Given this list of marker genes ANXA4, AXIN1, SAR1B, ABHD8, TLE3, TBX18, MIR519A1, MMP14 (matrix metallopeptidase 14), MIR107, ASH1L, MAPK8IP2, EMILIN1, ZNF675, SHISA6, MAPK14, PDE4D, RNF126, SH3RF1, EGFL7, NOTCH1, RASGRF1, PLK2, MIR23A, PRMT1, ARHGAP44, MIR19B1, RASA4B, MIR342, LDLR, THY1, MYOZ1, PTPRD, ADAR, ZGPAT, MIR4691, CLU, DUSP5, RRM2B, NDUFC2, ADORA1, SLC35C1, PTTG1IP, PRDX2, TRIM40, PDE3B, FHL2, ABCC8, HTRA2 (NCBI Gene Id 27429), MTNR1B, CTTN, OAS1, FOXO3, CHRD, PLEKHA1, IL1B, CSNK1E, PKIA, BCL9L (NCBI Gene Id 283149), CREB3L1, PTPRJ, NLRC3, RAB11FIP3, EGFR, PYCR1, CTH, SFRP5, ACVR1, FGF10, ARHGAP29, PELI3, CRH, CNOT2, KLF7, NCOR2 (nuclear receptor corepressor 2), GATA1 (NCBI Gene Id 2623), YWHAB, PRKCQ, PPM1A, USP25, TANK, METTL3, PAK5, OSM, PPM1B, RGS8, MINAR1, IQSEC2, SOD2, RGS16, RASA2, HMGA2, SEC13, PPP5C, FRZB, AMBP, GSTP1, HEY2, APPL1, SAG, TRIM67 (tripartite motif containing 67), VEPH1, MIR503, FMR1, SINHCAF, DEPDC5, VHL, IFI6, PLCL2, PBLD, CTNNB1, HMGXB4, RUNX2, NODAL, DSG3, PP2D1, FRMD8P1, GLI1, KCNB1, CD72, ENO1, NEDD4, MTOR, NOMO1, MIR125A, YTHDF3, CRY2, HLA-G, PDCD6, VSNL1, TGFBR1, MIR573, VRK3, OGT, TREX1, VWC2L, CACTIN, APC, GRB10, UBE2N, ACTN3, SRF, RGS6, RGS20, USP47, BARX1 (NCBI Gene Id 56033), TNF, WNT5A, RASSF2, TBC1D10C, SIN3A, TRIM60, PLD2, MIR27A, SOST, FKBP1B, MIR19A, SERPINE2, CAV2, ALPK2, NR2F2, TRIM15, GNAZ, PPT1, PPIA, BICD1, DEFB114, NPHP4, LMNA, TLR6, DLX2, FIGNL1, IGFBP2, MAPKBP1, CARD8, RNF43, ATF4, INS (NCBI Gene Id 3630), TWIST1, PDCD4, CD2AP, HSPA1B, CER1, MORN3, DUSP22, PPP3CB, XIAP, IL6ST, TLE1, CD160 (CD160 molecule), DUSP16, TNFAIP8L1 (NCBI Gene Id 126282), SPRED3 (sprouty related EVH1 domain containing 3), CIB1, UBE2D1, PHPT1, DEPTOR, AARS2, DKK3, BDNF, YWHAZ, GRID2IP, FGG, HIF1A, TP53, EID2, NDRG2, SCAI, KIF26A, AKT1, PRKCD, SAMTOR, IL1R2, IL36RN, NFATC4, OFD1, IL10, MAPK7, MVP, WDR24, HIC1, GABBR1, TAX1BP3 (Tax1 binding protein 3), PPP6C, IL6, MIR181A2, TMEM170B, TXNDC12, TMBIM6, KLF4, DAND5 (NCBI Gene Id 199699), MAPKAPK5, TRIM59, HADH, PPP2R1A, SERPINE1, DUSP6, IL17RD, TMBIM1, IRS1, TCF7L2, EPO, MFHAS1, PRDM15, PTPRR, CNOT7, CCDC125, APLNR, PIAS2, SYNJ2BP, PRKAR2B, XBP1, CCDC22, MCL1, CCDC88C, MIR206, DLX1, TRIAP1, OTUD3, NRROS, TERT, UFD1 (NCBI Gene Id 7353), LRRC14, ITPRIP, WFIKKN1, MIR130A, TAF9B, RTKN2, KIF7, LPAR1, MAP3K20, IL19, LBH, EZR, OTUD5, TBC1D7, DCST1, FERMT1, MYOC, MMP3, EPN2, KREMEN1, CAVIN3, RNF115, NPRL3, WWC3, MUC1, ELL3, RASL11B, HIPK3, SAP130, GRIK3, INSIG2, HHIP, CSNK1A1L, CARD16 (NCBI Gene Id 114769), PTPN2, MAP2K1, MIR302B, DUSP26, DDIAS, TLR4, SH2B3, RPGRIP1L, CXXC4, UBR5, PAQR3, UBASH3B, FFAR4, PEBP1, HERPUD1, ZNF653, DUSP1, CTHRC1, BMPER, ADRA2A, INHBA, IFT80, PTPRT, SLC24A4, PICK1, SEH1L, STK4, SOCS5 (NCBI Gene Id 9655), PTCH1, MIR221, WDR59, ATM, TRIM65, HDAC7, PYDC5, AATF, SMPDL3B, CFLAR, TMEM88, GRB14, CTNNBIP1, ACAA2, SLA2, LRP2, DYRK1A, LILRB2 (leukocyte immunoglobulin like receptor B2), SLIT3, PINK1, PELI1, SH3BP4, TNIP1, IL11, PPARA, MIR497, NRP1, CHRDL2, TMC8, NDUFAF2, MIR199B, MIR490, CDKN2D, CCAR2, CDH3, MMP12, SIRPA, IFT172, GRAMD4, EYA3, TMED2, RNF167, MAD2L2, STK11, GSK3A, TARBP2, ENG, GLIS2, NCOA5, NPY5R, CD44, YBX3, SIGIRR, VPS18, WNT11, LRRC32, SELENOS, C1QBP, BRMS1, ECM1, FBXW8, YAP1, RGS17, FBP1, CBLC, ZNF592, PIK3IP1, ACE2, THEM4, FBN2, PTPN12, DAB1, FXN, HMOX1, WWC2, SNCA, SREBF1, CLDN18, YWHAG, SMARCA4, HSPA1A, ADAMTS12, WWOX, DGKZ, KCTD6, GBP1, WTIP, PCBP2, STK3, LYPLAL1, CBY1, DHRS3, SUFU, HTT, BCL2L12, ADAMTSL2, ESR1, MARK3, OPRK1, PMCH, ACOD1, TLE5, KBTBD7, AARS1 (NCBI Gene Id 16), PSMD10, MIR185, CHD8, DDIT3, USP15, TRAP1, CD74, HDAC1, GRK3, CASTOR1, CSNK2A2, WNT1, TAOK3, MIR99A, OAS3, ATP2B4, CBL, RHOH, INPP5F (inositol polyphosphate-5-phosphatase F), SMAD7, FZD6, MIR29B1, PHLPP1 (NCBI Gene Id 23239), NEURL1, TPT1, BCL2L1, DLL3, RAB11FIP1, PER1, NLRP12, CHEK2, TLE7, ARHGAP25, CNKSR3, ANKRD6, CHP1, LITAF, HTRA3, DLK2, SIX3, ENTREP1, PRKAR2A, TACR2, ZC3H12A, DLG5, ADRB2, SLC39A8, CD22, MAGI2, PARP1, BMP8A, PXDN, RBPMS2, PIAS4, CHRNA7, DUSP9, GDNF, RGS14, PDX1, SLC25A31, CUL3, BMAL1, MIR483, SOCS3, ADRA2C, RGS19 (regulator of G protein signaling 19), SMPD3, PKHD1, CD46, SOX17, INPP5E, GATA4, TSC2, RASAL3, DNAJA3, NHERF1, WWC1, NOP53, NPHP3, DRD2, CDK5RAP3, WNK1, FKBP1C, SPAAR, MAP2K5, SCYL2, GTF2H2, TRIM39, NOC2L, HMGB2 (NCBI Gene Id 3148), PDE2A, PPEF2, SKOR2, TMEM161A, IKBKG, ZNRF3, MIR195 (microRNA 195), ARRDC1, SLC25A6, NXN, MIR564, USP49, MIRLET7B, EPHB2, MIR27B, ADNP, SPRED1 (NCBI Gene Id 161742), CCL5, FAM3D, LAMP2, NECAB2, ARHGAP45, TRIM11, SH3BP1, APOA1, LAX1, CISH, NFKBIL1, KLHL31, CRYBA1, STAP1, EPHA4, MIR103A1, IGF1R, MECOM, MIR372, TSPAN15, TMEM196, NME5, LEMD3, KCTD10 (NCBI Gene Id 83892), UBQLN2, BFAR, TTLL12, FST, KCTD13, AJUBA, PYDC2, DNAJA1, UBE2D3, STMN3, PCDH17, DHX58, GPR21, OPRM1, NR1H3, TAF9, SEC14L1, GMIP, ARID4A, NMB, SHISA3, CHST11, MIR133B, GPC3, RORA, SESN3, MIR200B, MET, CX3CR1, EYA4, ISG15, TRIM72, MIR361, PAFAH1B1 (NCBI Gene Id 5048), IGFBP4, RGS7BP, CASP8, RGS13 (NCBI Gene Id 6003), BMP4, PFKL, ZBTB7A, NKX3-1, ZNRF4, FZD9, HIPK2, PPP1R10, MIR376C, VPS25, APELA, PPP1R15A, CBFA2T2, HYAL2, UNC5B, JAGN1, NR0B1, MYOZ2, PPP2R3A, LZTR1, MIR18A, MIR133A1, SYVN1, SOCS6 (NCBI Gene Id 9306), LILRB4, PVRIG, DCN, CBLB, HIF1AN, NOL3, MIR146A (microRNA 146a), CTNNA1, GPR155, STRN3, CRY1, MIR145, IGFBP1, PTPRE, DYRK3, LATS1, FBLN1, STXBP1, ONECUT1, HOMER2, AKT3, PRELID1, PIP4K2C, MIR212, MIOS, SERPINB3, APLP1, LEMD2, AMER1 (NCBI Gene Id 160176), SPI1, MNT, SORCS2, SHH, NCOR1, H2BC11, ZFYVE28, HCN1, ENPP1, INPP5K, LGR4, OLFM4, FAF1, GPC1, GBP7, MIR302C, IRAK2, BRCA1, IGFBP6, IER3, MOCS2, PRKDC, RGS3, SKI, SNX13, ARHGAP35, RGS1 (regulator of G protein signaling 1), MBIP, SAP30L, NPRL2, HTR2A, APCDD1, NAIP, HTRA4, RAF1 (Raf-1 proto-oncogene, serine/threonine kinase), CPNE1, OTUD7B, GREM2, G3BP1, ROBO1, CNR2, ABL1, TMPRSS6, NFE2L2, RBX1, EGR1, QARS1, TBX20, PRNP, NF2, SNX25, SH2D1A, NEUROD1, EIF4E2, SIKE1, IRF4, MIR498, DACT2, DUSP8, APOD, PLAUR, DLL1, RASIP1, RPS6KA6, OPTN, LRPAP1, ATF3, ARHGAP12, LMBR1L (limb development membrane protein 1 like, NCBI Gene Id 55716), DUSP2, PSEN1, DYRK2, PTPRS, FOXO1, PTEN, BTNL2, DDIT4, DUSP13B, STAU2, TICAM2, HEG1, VWC2, RGS21, IRAK3, MIR223, MIR106A, RGS10, MRAP2, DLK1, NR1D1, MMRN1, TMEM127, LOX, C12orf43, SHISA2, PYDC1, GIGYF2, TMEM53, MIR210, PSCA, ISL1, BTN2A2, NKIRAS1, NOTUM, RB1, IVNS1ABP, CTDSPL2, HELLS, NF1, ASAH2, FOXM1, SPRY3, ARHGAP30, NR1H4 (NCBI Gene Id 9971), BCL3, CD3E, SIAH2, MIR203A, BLVRB, RGS2, PRKACA, CPTP (ceramide-1-phosphate transfer protein), STAT2, ABL2, PHIP, DKK1, SAR1A, AKT2, SORL1, UCHL1, PALM3, ADIPOR1, SLMAP, ABCA7, TLE6 (NCBI Gene Id 84846), GBA1, SAMHD1, RGS12 (regulator of G protein signaling 12), CSF2, MIR365A, MIR98, DUSP10, TNIP2, NOG, RPS6KB1, MIR766, BDKRB2, GGNBP2, RGS9BP, PLIN5, UACA, ZDHHC12, NKX2-5, CALR, MICOS10-NBL1, ARF1, GSC, P2RX7, GPX1, SMPDL3A, LEP, LAPTM5, MIR424, IGF1, VGLL4, MTMR4, PREX2, SARM1, PARL, MIR373, NCLN, FSTL4, ZNF451, RIPK1, HDAC2, MIR1271, TNR, MIR323A, IGFBP5, ASPN, BAX, DGKD, RB1CC1, PDE11A, TULP3, ZNF385A, RPS6KB2, MARCHF5, PHF14, CNOT9, GIPR, SOX2, GPR108, RAB11FIP5, MPV17L, HRG, PPARG (peroxisome proliferator activated receptor gamma), PSMD9, ING2, PPP3CA, BIRC6, KICS2, CX3CL1, PRAP1, TNFAIP6, FLCN, IL1A, MIR205, CGNL1, NLRP2B, ITGA6, PPP1R15B, EYA1, MIR26A1, ARRB2, STRAP, HUWE1, GHRL (NCBI Gene Id 51738), SGK3, GDF3, CIDEA, ADIPOQ, MIR34A, ATAD5, UBASH3A (ubiquitin associated and SH3 domain containing A), ZNF366, MIR508, LTBP1, AGER, SHANK2, MIR449A, SLC25A4, NKD1, IGFBP3, F2RL1, MIF, PRKAR1A, MIR100, MYOCD, GRK2, GCLC, OPA1, STUB1, BICC1, LATS2 (large tumor suppressor kinase 2), NPFF, MMP9, MIR138-1, MDFI, TGFBR3, SYT4, MIR135A1, DAG1, CCN3, NCOA2, TRIM33, RIPOR2, DACT3, RIOK3, TSPAN6 (NCBI Gene Id 7105), ITPR1, SHANK3, NCL, HERC2, TSG101, TMEM88B, SLC24A1, ITGB1, GPER1, MIR375, PRKCZ, FGA, MCC, FBN1, FFAR2 (free fatty acid receptor 2), DAB2, TNFRSF11B, CXCL8, NDRG4, FKBP1A (NCBI Gene Id 2280), BAK1, ACVR1C, SPINK1 (serine peptidase inhibitor Kazal type 1), HSPB1, SIRT7, SLC25A5, TSPO, IGBP1, MIR30C2, ADCY8, MDK, GATA2, SLC35F6, WIF1, NPY2R, FKTN, OTOP1, EZH2, LEPROT, MDM2, SPRY1, SOCS1, TPRG1L, LGALS3, PMEPA1, RABGEF1, BANF1 (barrier to autointegration nuclear assembly factor 1), SOCS7, ARHGAP42, CYLD, SORCS3, URI1, AURKB, SOX10, STAT1, IRAK1, MAPKAP1, EMD, MIR34B, TAF3, MIR149, PTPRU, RGS11, SOSTDC1, USP18, PIM3, SOX9, OVOL2, RNF213, VASN (vasorin), AKT1S1, MIR125B1, GNAI1, TNFAIP3, INSIG1, MIR200C, AR, LIMD1, TRABD2B (TraB domain containing 2B), CHMP6, MIR329-1, CXCL12, TSC1, MUL1, PIK3CB, HSPA8, MIR1224, YWHAE, KCNJ11, GRM2, MIRLET7F1, EDN1, MOB4, SOX13, CYRIB, SPSB3 (splA/ryanodine receptor domain and SOCS box containing 3), SMIM30, FAM89B, NPPA, KCTD11, DLL4, BANK1, SLC24A2, CIT, DUSP19, SRC, PBK, GATA3, PMCHL2, SKA3, CBLN1, ATAD3A, RHOA, TGFB2, RANBP9, APC2, PIP5KL1, MIR92A1, NKIRAS2, GRB7, PRKAR1B, NANOS3, CASTOR2, USP7, FYN (FYN proto-oncogene, Src family tyrosine kinase), RNF34, PTGIR, PTPN18 (NCBI Gene Id 26469), GRM5, ARID4B, NLRC5, PENK, RASA4, FRMD8, PIP4K2A, SDHAF2, CARD19 (caspase recruitment domain family member 19), GDF15, MAGEA1, FBXW7, ACKR3, WNK2, RBBP4, RIPOR1 (NCBI Gene Id 79567), GNAO1, ADGRG3 (NCBI Gene Id 58870), VPS11, SPRED2, SLC6A4, ING1, TLR9, TAX1BP1, MLXIPL, MIR29C, FSTL3, SLC8A3, MIR15B, UBE3A, SEMA6A, PRDM14, SESN2 (sestrin 2), WDR91, GPATCH3 (NCBI Gene Id 63906), FOXP1, CAV1, TAF1, LONP1, BRD4, SUDS3, PAK1IP1, NKX2-1, SFRP4, CRTC3 (NCBI Gene Id 64784), MIR199A1, MIR15A, MIR140, KANK1, MIR181B1, ABHD17A (NCBI Gene Id 81926), ERRFI1, PCSK9, C1QL4, MIR9-1, ENY2, THBS1, EPHA7, MIR24-1, PEA15, LILRA4, IFI16, UBR1, GIT1, MESP1, FOXH1, RITA1 (NCBI Gene Id 84934), PPIF, CD109, ARHGAP24, PTPRC, BCL6, CHRNA9, ADA, UBR2, SESN1, IL12A, DLC1, RGS4, LDLRAD4, NPC1, DUSP4, TWSG1, NGFR, ATXN3L, SMURF2, NLRP3, RASAL1, TPBG, SMAD5, DRD5, GRID2, MFN2, MSTN, ATXN3, SH3GL2, DKK2, DDX3X, GRIA1, MIR222, GPRASP1, PPP2CA, MEN1, MIR92B, PRRT1, MAPT, DNAJB9, BCL2, SYNGAP1, CD38, ZMYND11, ARHGAP22, PRDM16, SOCS4, DDRGK1 (DDRGK domain containing 1), RASA3, DEFB118, MIR214, HDAC3, BRAP, LRP4, INPP5D, VCP, UCN, CDH2, SH3RF2, TMEM131L, PEG10, RPS6KA1, LILRA2, RGS7, YJU2, HIGD1A, RGS18, TMSB4X, DUSP29, BMP5, SQSTM1, ATXN1, SNIP1 (NCBI Gene Id 79753), TMEM14A, CYP26C1, PIP4K2B, ERBIN, BCHE, MAD1L1, SFRP1, ADGRA2, APOE, GPR161, CD200, MIR93, CSK, GREM1, CHGA, CHRDL1, GAS6, CUL7, ARR3, MIR519D, MARCHF7, SIRT4, TYRO3, MIR34C, APCDD1L, RELA, MGRN1, BRMS1L, HERC4, LRP1, ITGA3, COMMD1, ADRB3, CEACAM1, CDK12 (NCBI Gene Id 51755), MIRLET7E, NCK1, SMAD6, KBTBD6, RBMS3, IL7, KCTD21 (potassium channel tetramerization domain containing 21), UBAC2, NMI, MIR520C, SZT2, ELF1, SNX6, MAZ, PF4, GHSR, MOSMO, IFI35, LPXN, LEPROTL1, RUBCN, LZTS2, PRKAA1, CREB3, PHACTR4, TP63, ONECUT2, DKK4, EFNA1, FNIP1 (folliculin interacting protein 1), MPIG6B, PDE3A, TCIM, TLE4, CDK20, ARG1, SPRY2, FGF2, TOB1, GPR37L1, PCGF2, ITCH, NOS3, RBBP7, FCRL3, MMRN2, RGS22, WNT16, TRIB3, TPBGL, ARMC10, PPP2CB, AMFR, CRIM1 (NCBI Gene Id 51232), MARVELD3 (NCBI Gene Id 91862), SLAMF1, IGSF1, CRKL, SLC8A1, RNF125 (NCBI Gene Id 54941), MAPK3, AP1AR, MIR204, GNAI2, UBE2W, ERFE, FAIM2, PHB2, GLG1, HJV, CDK3, MIR142, MIR141, APP, DICER1, PDE8B, RPH3AL, RGS5, MIRLET7A1, UCP2, LTF, FGB, INVS, HECW1, NRARP, PRR5L, NLRX1, ARRDC3, LFNG, CLOCK, DRD1, PRAME, STRN4, GLI3, PRKACB, HAPSTR1, FGF23, GRINA, FBXO7, MIR20A, ENDOG, ADM, MIRLET7C, STRADB, SPRY4, MRAP, DUSP7, MIR132, PTPN3, ARRB1, CHAC1, WWTR1, PRICKLE1, RCAN1, ITGB1BP1 (NCBI Gene Id 9270), PID1, SULF1, ARHGAP17, BECN2, INHBB, TNFAIP1, GSK3B, NLK, PIBF1, CTNND1, SLC27A4, MAGEA3, SOCS2, NR4A2, CGAS, ZNF536, PDE10A, LMO3, TLE2, HEYL, RNF113A, MTM1, IRGM, MEGF8, MIR101-1 (microRNA 101-1), IFT122, SCRT2, ERBB3, LRRK2, STAMBP, LGMN, CADM4, FCGR2B, PLK3, SNAI1, RACK1, MYC, TRABD2A, FGF9, PSME3, ACHE, CRHBP, TSKU, DAB2IP, ARC, INPP5A, MIDN, IL1RN, PHLDA3, WFIKKN2, CSNK2A1, PDE4B, PTPN6, SIRT3, PALM, NUP62, MAD2L1BP, TREM2, REST, LIF, TKFC, MIR152, TCF21, MIR708, COL2A1, MLLT3, MIR340, HGF, ITGA1, SPART, FOXJ1, MEFV, SMAD4, ITGAV, APLN, C8orf44-SGK3 (NCBI Gene Id 100533105), RNF149, PTGS2, ULK3, BOK, TNIP3, USP20, SMPD1, DACT1, BPIFB1, TNS2, INHA, RGS9, SKA1, MIR21, HYOU1, SBNO1, BMP7, HTRA1, SULF2, GPRC5A, GPS2, HEY1, CLEC12B, RNF152, PFDN5, PAWR, MIR874, CHRNA10 (NCBI Gene Id 57053), SFRP2, LACRT, BIRC7, SKOR1, KANK2, SNX5, TGIF1, MIRLET7G, TMEM64, OTUD4, CCDC3, ATF6B, ABHD6, CYP7B1, DKKL1, BEND6, BAG5, TRAT1, RFX4, EIF3A, RAB7A, BID (BH3 interacting domain death agonist), CD300LF, TRAIP, HGS (NCBI Gene Id 9146), STAT3, PADI2, HOMER3, MIR17, ADAM17, HHEX, AGT, CNOT1, STMN1, GCLM, PARK7, AGTR2, SIRT1, SKIL, MIR665, MIR885, ACP4, BMP2, PREX1, MIR29A, SMURF1, CSNK1A1, NKD2, NLRP2, YTHDF2 (NCBI Gene Id 63042), EPM2A, CCNC, SLIT2, MIR218-1, NRG1, NHERF4, GHITM, NBL1, STRIP1, CREBRF, MKRN2, ITPRIPL1 (ITPRIP like 1), NR1H2, MIR26B, FUZ, TET1, WNT5B, TRIB1, ZDHHC18, MAPK8IP1, RUVBL2, WWP2, RFFL, PTPRO, DRD3, CD300A, TRAF3IP1, PRKN, BTRC, DDIT4L, PTPN22, DUSP3, KCNK9, MIR1-1, NPLOC4, CILP, TRIM31, FAIM, PYCARD, SCG2, KDM1A, UBQLN1, BMI1, AZI2, SRMS, DRAXIN, PIK3R2, HSPA5, SIRT2, VPS13A, KPTN, JADE1, TRIM32, WNT4, NFKBIA, CARTPT (NCBI Gene Id 9607), ARHGEF2, NPVF, WFS1, RRN3, AIDA, ATAD1, BAMBI, STK38, AHSG, PLEK, TBK1, CASTOR3P, STYXL2, NCK2, LYN, CAV3, HACD3, PRKCB (NCBI Gene Id 5579), SYTL4, SNAI2, EYA2, PTPN1, CYP26A1, ANGPT1, CALCA, AXIN2, INTS9, DGKG, EGLN1, AMER2, CYP26B1, NOMO3, PHB1, SLC2A10, MAP2K3, MIR16-1, PDPK1, ICAM1, ITFG2, CITED1, GRIK2, ASXL1, C1QTNF3, DLG1, RAB7B, SIVA1, UCMA, GFRAL, INPPL1, USP10, FBXL2, UFL1, SAP30, SOX30, PTPN11, RNF39, PRKAA2, NLRP6, NONO, C3orf33, KLK14, PIN1, FZD1, GJA1, AIM2, PARP14, PTCH2, IL12B, here is a description of the gene set: Any process that stops, prevents, or reduces the frequency, rate or extent of a signaling process. studied in species Homo sapiens Human Gene Set: GOBP_NEGATIVE_REGULATION_OF_SIGNALING